Given this list of marker genes GRIP1, RAB26, VAMP4, RILPL2, ANK3, CSK, CLN3, COMMD1, GGA1, ATP2C1, RAB7A, RAB31, SPTBN1, RILPL1, SYS1, KIF13A, GOLGA4, VAMP2, SCARB2, MACF1, RAB10, RAB34, TRARG1, LYPLAL1, GORASP1, RDX, GRIP2, KRT18, ARHGAP44, BBS2, ATP6AP1, AKAP5, RSC1A1, RACK1, CNST, VPS35, AFDN, BLZF1, GOLPH3, NECTIN3, VAMP3, LYPLA1, GOLPH3L, ARFRP1, ACSL3 (acyl-CoA synthetase long chain family member 3), RAB8A, GRIPAP1, GCC2, LRRC7, AMN, NSG1, BBS1 (NCBI Gene Id 79702), RAB11A, GGA2, PHAF1, PKDCC, NSF, VAMP5, PREPL (prolyl endopeptidase like), GORASP2, SORL1, ARL6, OPTN, GOLGA7, ANXA13, SCRIB, GGA3, RAB11FIP3, ZDHHC2, here is a description of the gene set: Human Gene Set: GOBP_ESTABLISHMENT_OF_PROTEIN_LOCALIZATION_TO_PLASMA_MEMBRANE The directed movement of a protein to a specific location in a plasma membrane. species: Homo sapiens